The following is a description of a gene set: Mouse Gene Set: REACTOME_PINK1_PRKN_MEDIATED_MITOPHAGY PINK1-PRKN Mediated Mitophagy studied in species Mus musculus, and this is the list of marker genes: Atg9a, Tomm20, Ubc, Tbk1, Uba52, Mfn1, Ube2l3, Tomm7, Map1lc3a, Ube2v1, Pink1, Vdac1, Tomm6, Mterf3, Tomm40, Vdac3, Atg5, Mfn2, Prkn, Ubb, Vdac2, Uba52rt, Ube2d3, Rps27a (ribosomal protein S27A), Optn, Tomm22, Ube2n, Atg12, Ube2d2a, Tomm70a, Map1lc3b, Sqstm1, Tomm5